Given this list of marker genes EED, IFFO2, TMA16, DOK1, RFC5, IFNAR1, ARID5A, TPRKB, IL18, GEM, EVL, UBE2J2 (ubiquitin conjugating enzyme E2 J2), KAT6A, RAD9A, ZFAND2A, TMEM129, DNAJC12, CFLAR, CCR5 (C-C motif chemokine receptor 5), NFKBIB (NCBI Gene Id 4793), C2, PRRG2, C8orf33, WNK2, GHITM, ZNF227, MRPS6, TAP2, TRIM26, CCR7, PIM1, TOX4, INHBA, DPF2, BID, CFAP298, TRHR, STAB1, CACNG1, ADORA2B, PSME4, IL2RG, CLN8, SH3BP2, ERGIC1, HLA-C, PKIG, SERTAD1, SLCO3A1, TIGD5 (NCBI Gene Id 84948), HFE, VAV3, BMI1, IER5, MOB2, IL15RA, PTPN18, KPNA3, MTMR2, ANKIB1, ABHD16A, AIF1, GNA11, RBM7, MRPL40, AIDA, FNBP4, PIAS1, LAMP2, PPP4R2, CSRP1, ELK3, NAXE, RGS14, AGRN, TARDBP, TMCC3, HASPIN, FTL, GLIPR2, PTTG1, SMIM8, SOCS4, SPRED1, PHC1, HSPA1B, RASA3, NUBP2, NOP53, ANXA4, TGFBI, SERPINC1, CFAP20, MRPL4, ANPEP, COPG2IT1, HDC, ATXN7L1 (ataxin 7 like 1), WAC, ATP6V1D, FMR1, ANKFY1, KEAP1, NUP50 (nucleoporin 50), LRRC4 (leucine rich repeat containing 4), CD247, MYL7, ZNF24, F11R, DXO, CDS2, GBP2, PLAT, CD80, SCNM1, FNDC3A, SORL1, TIAM1, ADRB1, ISG15, IL12B, UPK3B, PITPNM1, SNX10 (sorting nexin 10), TNFSF4, LARP1, BHLHE40, SUPT20H, TPRA1, CCL17, MRPL54, TMCO3, COMMD9, PDE4A, DHRS7B, PKIB, ITGB7, SCARB2, GPR137B, LYZL1, RIPK2, MCM6, POR, DBNL, MVB12A, FASTKD2, KATNA1, SMIM3, CDKN2B, TRIM25, ASGR2 (NCBI Gene Id 433), PHYH, ITPR1, WIPF1, RSL24D1, EPPIN (epididymal peptidase inhibitor), SORCS2, PFKFB3, FCGR2B, LAPTM4A, ANAPC16, KCTD14, SGCB, CST3 (NCBI Gene Id 1471), SLC37A2, TXNDC17, CD70 (NCBI Gene Id 970), ICAM5, RABEPK, FYN, PSPH, BAIAP2, ETV6, PIGH, LGALS3, NEK7, ETAA1, ACTN1, NRL, NDST4, LPXN, CLIC4, GLRX, ARF4, PLOD3, LRRC41, SDHAF2, C9orf85, PTK6, HMGA1, C14orf119, CEPT1 (NCBI Gene Id 10390), ADRA2C, CD274, SLC25A10, ARPC2, CASP3, RBM43, DHPS, ACSL1, here is a description of the gene set: from publication Amit I, Garber M, Chevrier N, Leite AP, Donner Y, Eisenhaure T, Guttman M, Grenier JK, Li W, Zuk O, Schubert LA, Birditt B, Shay T, Goren A, Zhang X, Smith Z, Deering R, McDonald RC, Cabili M, Bernstein BE, Rinn JL, Meissner A, Root DE, Hacohen N, Regev A (PMID 19729616) Genes up-regulated in comparison of dendritic cells (DC) stimulated with LPS (TLR4 agonist) at 16 h versus DC cells stimulated with Pam3Csk4 (TLR1/2 agonist) at 16 h. Human Gene Set: GSE17721_LPS_VS_PAM3CSK4_16H_BMDC_UP species: Homo sapiens mouse primary BMDCs were stimulated with tlr ligands and gene expression changes were profiled on Affymetrix arrays